The following is a description of a gene set: Human Gene Set: GOMF_THIAMINE_TRANSMEMBRANE_TRANSPORTER_ACTIVITY Enables the transfer of thiamine from one side of a membrane to the other. Thiamine is vitamin B1, a water soluble vitamin present in fresh vegetables and meats, especially liver. species: Homo sapiens, and this is the list of marker genes: SLC22A1, SLC19A2, SLC25A19, SLC19A3, SLC44A4, SLC47A1, SLC22A2